The following is a description of a gene set: species: Mus musculus Mouse Gene Set: GOMF_TRANSLATION_INITIATION_FACTOR_BINDING Binding to a translation initiation factor, any polypeptide factor involved in the initiation of ribosome-mediated translation., and this is the list of marker genes: Eif2s2, Rps19, Trim32, Eif5, Cacna1c, Polr2g, Lin28a, Eif2ak3, Larp1, Fmr1, Bc1, Celf1, Zpr1, Nck1, Eif4ebp2, Syt11, Gle1, Dapl1, Eif3c, Eif2ak4, Tbl2, Rps24, Eif2b5, Eif4e, Polr2d, Angel1, Eif3m, Eif3b, Eif3f, Rbx1, Hhex, Eif4ebp3, Eif4g1, Rps3a1, Eif2b4, Ddx3x, Eif4ebp1, D1Pas1 (DNA segment, Chr 1, Pasteur Institute 1)